Given this list of marker genes Shox2, Pgap6, Tmem35a, Zdhhc2, Tom1l1, Mapk14 (NCBI Gene Id 26416), D17H6S53E (NCBI Gene Id 224726), Tmem51, Yipf1, Cttnbp2, Zfp608, Stk35, Ppm1b, Zfhx2, Ccdc192, Lrfn3, Kptn, Rnf169, Mast3, Sertad4, Slc30a6, Arhgap42, Slc43a2, H1f0, Tnfsf13b, Zfp329, Pag1, Snap29, Ceacam5, Cst7, Bag4, C9orf72, Kcnb1, Mfsd14b, Slc6a17, Sox6 (NCBI Gene Id 20679), Ubn1 (NCBI Gene Id 68719), Tfeb, Dennd2c, Cpsf7, Med13, Mef2d, Gbf1, Ccdc86, Pabpc4l, Kcnk13, here is a description of the gene set: species: Mus musculus Genes predicted to be targets of miRBase v22 microRNA mmu_miR_5626_5p in miRDB v6.0 with MirTarget v4 prediction scores > 80 (high confidence targets). from publication Chen Y, Wang X (PMID 31504780) Mouse Gene Set: MIR_5626_5P